The following is a description of a gene set: The gene expression program underlying the specification of human cell types is of fundamental interest. The study authors generated human cell atlases of gene expression and chromatin accessibility in fetal tissues. For gene expression, the study authors applied three-level combinatorial indexing to >110 samples representing 15 organs, ultimately profiling ~4 million single cells. The study authors leveraged the literature and other atlases to identify and annotate hundreds of cell types and subtypes, both within and across tissues. Our analyses focused on organ-specific specializations of broadly distributed cell types (such as blood, endothelial, and epithelial), sites of fetal erythropoiesis (which notably included the adrenal gland), and integration with mouse developmental atlases (such as conserved specification of blood cells). These data represent a rich resource for the exploration of in vivo human gene expression in diverse tissues and cell types. Marker genes curated from the annotated cluster as represented in the Descartes Human Gene Expression During Development database. Human Gene Set: DESCARTES_MAIN_FETAL_ENS_GLIA from publication Cao J, O'Day DR, Pliner HA, Kingsley PD, Deng M, Daza RM, Zager MA, Aldinger KA, Blecher-Gonen R, Zhang F, Spielmann M, Palis J, Doherty D, Steemers FJ, Glass IA, Trapnell C, Shendure J (PMID 33184181) studied in species Homo sapiens, and this is the list of marker genes: PAQR6, DLX1, OSGEPL1-AS1, AP1S2, WDR86, OR4N2, ENPP7P2, MVB12B, METRN, GFRA1, DNAJC1, PDCD4-AS1, ARTN, RABEPK (Rab9 effector protein with kelch motifs), GAS7, LINC01474, COL20A1